Given this list of marker genes MPZL2, CXCL8, FNBP1, CYTIP, CD200, PMCH, AREG, HLA-DPA1, ADAM28, CXCL3, SELL, LIMCH1, TNFSF10, HLA-DQB1 (NCBI Gene Id 7924), DUSP6, CTSO, GLIPR1, TPBG, TCEAL2, TSPAN6, PTGER4, TRIM22, BIRC3, RABGAP1, HLF, NFAT5, TCF7L2, BAALC, FAM30A, CXCL2, NRIP1, CXCL6, INHBA, MYO5C, ADGRG6, CD59, VNN1, IL18R1, RPL31, ANXA5, MLLT3, DMD, MIR22HG, CD40, TSPAN31, ALOX5, CH25H, HCP5, SH3BP5, CXCL1, OPTN, CLEC2B (C-type lectin domain family 2 member B), H1-0, ERG, CEP15, AKR1C3, H2AC6, PCDH9, CCL19, GBP2, NEAT1, ARMCX2, EVI2A, CXCL13, GABPB1-IT1, IFI16, TGFB1I1, ADAM8, CCNG2, CRHBP, IDS, HLA-DRB4, SVIL, RBPMS, PPFIBP1, SPTBN1, TNFSF4 (NCBI Gene Id 7292), TM4SF1, TCF4, HLA-DQA1, CREM, ENPP4 (ectonucleotide pyrophosphatase/phosphodiesterase 4), SORL1, CXCL11, EMP1, TFPI, H2BC21, PTPRC, HLX, GUCY1A1, BCL11A, CD44, SOD2, IL1B, here is a description of the gene set: Human Gene Set: GRAHAM_CML_DIVIDING_VS_NORMAL_QUIESCENT_DN from publication Graham SM, Vass JK, Holyoake TL, Graham GJ (PMID 17717066) Genes down-regulated in quiescent CD34+ cells isolated from peripheral blood of normal donors compared to the dividing cells from CML (chronic myeloid leukemia) patients. studied in species Homo sapiens Quiescent and dividing hemopoietic stem cells (HSC) display marked differences in their ability to move between the peripheral circulation and the bone marrow. Specifically, long-term engraftment potential predominantly resides in the quiescent HSC subfraction, and G-CSF mobilization results in the preferential accumulation of quiescent HSC in the periphery. In contrast, stem cells from chronic myeloid leukemia (CML) patients display a constitutive presence in the circulation. To understand the molecular basis for this, we have used microarray technology to analyze the transcriptional differences between dividing and quiescent, normal, and CML-derived CD34+ cells. Our data show a remarkable transcriptional similarity between normal and CML dividing cells, suggesting that the effects of BCR-ABL on the CD34+ cell transcriptome are more limited than previously thought. In addition, we show that quiescent CML cells are more similar to their dividing counterparts than quiescent normal cells are to theirs. We also show these transcriptional differences to be reflected in the altered proliferative activity of normal and CML CD34+ cells. Of the most interest is that the major class of genes that is more abundant in the quiescent cells compared with the dividing cells encodes members of the chemokine family. We propose a role for chemokines expressed by quiescent HSC in the orchestration of CD34+ cell mobilization. Disclosure of potential conflicts of interest is found at the end of this article.